The following is a description of a gene set: from publication Berger J, Sansom O, Clarke A, Bird A (PMID 17353267) Mouse Gene Set: BERGER_MBD2_TARGETS Genes strongly up-regulated in colon tissue upon MBD2 knockout. Gene expression in the gut is segmentally regulated, but little is known of the molecular origin of patterning. Analysis of gene expression in colons from mice lacking the methyl-CpG binding repressor MBD2 revealed frequent activation of genes that are normally only expressed in the exocrine pancreas and duodenum. Reduced DNA methylation activated the same gene set in the colon. No significant differences in DNA methylation between the colon and duodenum were detected, but MBD2 was significantly more abundant in the colon. The relevance of MBD2 concentration was tested in a human colon cancer cell line. Depletion of MBD2 was again found to activate exocrine pancreatic genes. Gene activation in this cell culture model was accompanied by loss of promoter-bound MBD2 and increased histone acetylation. The results suggest that modulation of MBD2 during gut development establishes a region-specific gene expression pattern that is essential for establishing correct segmental character. studied in species Mus musculus, and this is the list of marker genes: Amy2a5, Rnase1, Cela2a, Prss2, Cel, Reg2, Tff2